Given this list of marker genes Rps27a, Rfc3, Rev3l, Rpa1, Ubb, Poli, Pcna, Mad2l2, Rfc1, here is a description of the gene set: Reactome Pathway: Translesion synthesis by POLI studied in species Mus musculus part of: Translesion synthesis by Y family DNA polymerases bypasses lesions on DNA template electronically inferred by orthology from the curated human pathway This event has been computationally inferred from an event that has been demonstrated in another species.<p>The inference is based on the homology mapping from PANTHER. Briefly, reactions for which all involved PhysicalEntities (in input, output and catalyst) have a mapped orthologue/paralogue (for complexes at least 75% of components must have a mapping) are inferred to the other species.